The following is a description of a gene set: Developmental hypoplasia of the cochlea. Human Gene Set: HP_HYPOPLASIA_OF_THE_COCHLEA Hypoplasia of the cochlea species: Homo sapiens, and this is the list of marker genes: NEUROG1, FOXP2, SIX5, DDX11, SLC26A4, KCNJ10, EYA1, FOXI1, SIX1